Given this list of marker genes MAN2A2, CCND2, HYI, SNX29, ARL4C, DBP, ZNF276, TNFRSF4, GPRASP2, CDYL2, CRIM1, NXF1, COQ8A, QPRT, SRGAP2, PEAK1, MGRN1, TTC39B, TAGAP, CPNE7, HARS2, ZXDB, SCML4, ZNF76, FYCO1, NOTCH3, PDE7A, KLHL24, PPP1R3F, HYAL2, AMIGO1, JUN, TEF, SMAD7, ADRB1, SRSF2, NOP14, UBXN11, CREB3, PFN2, FBXW4, C19orf38, ZEB2, GGA1, CAMK2N1, CIPC, PHF3, ENO3, IFFO2, ARFRP1, GIMAP6, RBM48, FNDC5, COL6A5, PLEKHA6, EHD3, EIF5, SMPD5, TUFM, METTL3, TMEM121, SNHG12, GUCA1B, FCGR2B, FHIP2A, TFAP4, IER5, ABTB3, TMPRSS3, LEMD2, BBS2, CARNS1, OPLAH, ASB13, KRT78, GAPVD1, ANKHD1, CCDC137, PDE2A, LRP6 (NCBI Gene Id 4040), PAXBP1, BCL2, OTUD1, GRAMD2B, LPIN1, ARHGEF4, PARP8, LATS2, MTFR1L, BCL6, DMRTA1, CCNL2, GAA, SFI1, SPRY2, SOX12, CREBL2, NR1D1, STON2, MARCHF9, MTMR4, MGA, RCCD1, TARBP2, NUDT16L1, POGK, UNC45A, PIK3IP1, ERCC1, HECA, ATXN7, PDXK, ATP6V0B, USP24, DHX33, RABL6, SLC38A2, MAFK, CARD6, CNOT4, SLC5A6, EIF4A2, STXBP4, SRSF6, S100PBP, SBSN, PRRT1, EGR3, CLCF1, P4HTM, CIRBP, IL18RAP, TCEA2, ESS2, SMYD5, C9orf50, SLC12A5, AP5Z1, KLHL17, MYLIP, RELL2, NR1D2, ZHX2, PHF21A, ADPGK, CLK1, RFX5, AGO1, KDM5B (NCBI Gene Id 10765), CRYBG2, TSHZ3, TDRP, ZBTB4, FAM8A1, GGA3, TAFAZZIN, CREBRF, KCNJ8, IFT140, PANK1, TNFRSF25, CISH, NMNAT3, HNRNPH3, SHPK, ADGRG5, SOCS3, AGPAT2, ELMOD3, LRATD2, IL7R, S1PR5, AOAH, GSDMD, CLTB, CAMSAP2, SEC16A, CBX7, BCL2L2, TELO2, ZNF318, MTURN, SNORD123, KMT2C, TNFRSF18, COG8, PRKCE, TM6SF1 (NCBI Gene Id 53346), TMEM201, PISD, ZFP36L1, MPPE1, MDC1, ITGA3, CCL4, SLFN13, SLC20A1, FAM210B, NFKBID, here is a description of the gene set: from publication Pearce EL, Walsh MC, Cejas PJ, Harms GM, Shen H, Wang LS, Jones RG, Choi Y (PMID 19494812) Genes down-regulated in comparison of wild type CD8 effector T cells at day 6 versus those from mice defficient for TRAF6 at day 10. CD8 T cells play a crucial role in immunity to infection and cancer. They are maintained in constant numbers, but upon stimulation with antigen undergo a developmental program characterized by distinct phases encompassing the expansion and then contraction of antigen-specific populations, followed by the persistence of long-lived memory cells. Although this predictable pattern of a CD8 T cell response is well established, the underlying cellular mechanisms regulating the transition to memory remain undefined. Here we show that TRAF6, an adapter protein in the TNF-receptor (TNFR) and IL-1R/TLR superfamily, regulates CD8 T cell memory development following infection by modulating fatty acid metabolism. We show that mice with a T cell-specific deletion of TRAF6 mount robust primary CD8 T cell effector responses, but have a profound defect in their ability to generate memory. This defect is CD8 T cell intrinsic and is characterized by the disappearance of antigen-specific cells in the weeks following primary immunization. Microarray analyses revealed that TRAF6-deficient CD8 T cells from early timepoints following immunization exhibit altered expression of genes that regulate fatty acid metabolism. Consistent with this, activated CD8 T cells lacking TRAF6 are unable to upregulate mitochondrial β-oxidation in response to growth factor withdrawal in vitro. Treatment with drugs that induce fatty acid oxidation enabled CD8 T cell memory generation in the absence of TRAF6. Remarkably, these treatments also increased CD8 T cell memory in wild type mice, and consequently were able to significantly improve the efficacy of an experimental anti-cancer vaccine. Human Gene Set: GSE15750_DAY6_VS_DAY10_TRAF6KO_EFF_CD8_TCELL_DN studied in species Homo sapiens